The following is a description of a gene set: from publication Chen Y, Wang X (PMID 31504780) Human Gene Set: MIR6819_5P species: Homo sapiens Genes predicted to be targets of miRBase v22 microRNA hsa-miR-6819-5p in miRDB v6.0 with MirTarget v4 prediction scores > 80 (high confidence targets)., and this is the list of marker genes: ZFHX2 (zinc finger homeobox 2), IQGAP3, LCE2C, SPRED3, ZNF774, RAD51B, GPR82, GRM6, NUDT4, CCT8L2, GRIN2A, MUC17, SLC48A1, ARL17A (ADP ribosylation factor like GTPase 17A), MCCD1, MROH6, UBE2W, AGK, SLC13A5, TMCC3, RS1, DHX8, NRXN2, GUCD1, GTDC1, HTR3D, ARRB1, CRACD, FABP2, ZDHHC3, SRGN, WWTR1, AAK1, MEF2D, PRAF2, SETD9, HECW1, HTR3C, RNASEH2C, ZNF579, FBXO46 (NCBI Gene Id 23403), PAFAH1B2, CSAG3, B3GALT5, PPP1R9B, CSAG1, SH3PXD2A, FCRLA, DLK1, ASAH2B (NCBI Gene Id 653308), TRIQK, PIGL, AGAP1, POLR3C, ZNF345, CPNE5, RNF2, MINAR1, CHD6, PATZ1, ITPRIPL2, RCC2, DNAJB4, GREM1, ITPKC, KSR2, CFL1 (cofilin 1), EGFR, MDM4, AK7, CLIP3, GFAP, FCER2, DNAJC8, MAP1A, LINC03042, CPNE3, TMEM222, PPP6C, IFFO2 (NCBI Gene Id 126917), SLC25A23, CC2D1A, ACSM2A, COL11A2, KCNC4, DLL3